Given this list of marker genes DALRD3, VAC14, ARFGEF1, HOXA7, IL7, LY75, ATP2C1, IRF8, CCNB1IP1, MUSK, SDC3, DAXX, CEP350, ICAM1, STS (NCBI Gene Id 6802), SLC8A1 (solute carrier family 8 member A1), AHR, SPATA6, REN, ROCK2, FAM83F, ENTPD1, SLC18A3, ARHGAP39, PEX11A, GDF5, HNRNPD, CXCL3, IKZF1, ELF5, CASP2, TAP1, CLEC4E, CCDC152, RGS14, NAA30, FPR2, RFC5, PIGA, CFDP1, DCK, TRAPPC14, RSAD2, LMO4, STXBP1, DRG1, RARA, TCF20, TSPO, TPO, KLHL24, BRD4, SNX10, ZC3H12C, BLTP3A (bridge-like lipid transfer protein family member 3A), ACSL1, MX2, CD38, HLA-DOB, PHKG2, AGTRAP, LY6E, ACO2, CFLAR, KAT2B, AOAH, STX2, USO1, PSMB8, NFKBIE, ZNFX1, CPT1A, GBP7, SEMA4A, BPNT2, PKP4, AQP9, RO60, PGAP4, ZBTB7A, DDX10, IFIT3, TENM1, CARS1, CYBB, KLF13, IRF7, SGPL1, MYO10, LPP, IL5RA, KDM5B, MT2A, GJA10, SERPINB9, UTRN, CH25H, F3, FGF17, IFIH1, CXCL10, SIN3A, LCP2, GPC1, HLA-E, COPB2, RRM2, LDHA, ZFHX3, MLEC, HIF1A, ACSM3, DLX6, ARL5A, UBD, SOD2, INPP5B, SPIC, PLPP3, PITX2, CRABP2, C3, SPINK1, HOMER1, CLDN11, SNX6, NUPR1, SLFN12L, S100A8, AXL, MAGEB4, GALNT10, RAB5C, DVL1 (NCBI Gene Id 348497), AFF1, ARG2, ADGRE1, SEC23B (NCBI Gene Id 980), NOTCH1, SLC19A1, ZNF281, IRGM, CASK, RNF19B, NMT2 (NCBI Gene Id 9397), WAC, CUL2, SLC4A1AP, SLC22A2 (solute carrier family 22 member 2, NCBI Gene Id 6582), CLIC4, SEPHS2, IFIT1B (interferon induced protein with tetratricopeptide repeats 1B), HLA-DRA, TRIB3, TBPL1, PLPP1, GBP4, ETF1, NHSL3, RWDD1, INHBA, PPA1, POLR1B, CD1D, PRDX1, USP18, ATP1A2, ZFP57, NAMPT, N4BP1, IL10RA, ABCC5, CAPZB, SUSD6, ISG15, RGCC, SNHG6, TRPC6, DFFA, HLA-DMB, RBP2, HSDL2, TRIM21, STAT3, ITPR2, VNN2, GARS1, GNPTAB, FPR1, CD74, HLA-DRB1, BMS1, UTP20, PI4KA, GLA, MTF1, NUP62, HLA-DQA1, CPXM1, NPY5R, here is a description of the gene set: Human Gene Set: GSE5679_CTRL_VS_PPARG_LIGAND_ROSIGLITAZONE_AND_RARA_AGONIST_AM580_TREATED_DC_UP studied in species Homo sapiens Our data indicated that activation of the PPARg nuclear receptor induces a retinoid response in human dendritic cells. In order to assess the contribution of retinoid signaling to the PPARg response we decided to use a combination of pharmacological activators and inhibitors of these pathways. Cells were treated with the synthetic PPARg ligand rosiglitazone (RSG), or with RSG along with the RARa antagonist (AGN193109) to block RARa mediated gene expression, or the RARa specific agonists (AM580) alone. This design allows one to determine if retinoid signaling is a downstream event of PPARg activation and what portion of PPARg regulated genes are regulated via induced retinoid signaling. from publication Szatmari I, Pap A, Rühl R, Ma JX, Illarionov PA, Besra GS, Rajnavolgyi E, Dezso B, Nagy L (PMID 16982809) Genes up-regulated in monocyte-derived dendritic cells: untreated versus rosiglitazone and AM580.